The following is a description of a gene set: A decreased concentration of protein in the blood. Hypoproteinemia studied in species Homo sapiens Human Gene Set: HP_HYPOPROTEINEMIA, and this is the list of marker genes: DCLRE1C, PRF1, NPHS1, B2M, RAG1, FOCAD (focadhesin), RAG2, TMPRSS15, UBR1, LAMB2, ACADVL, ALB, CD55, NOS1AP, LYST, DPAGT1 (dolichyl-phosphate N-acetylglucosaminephosphotransferase 1), RBCK1, SLC25A13